The following is a description of a gene set: The process whose specific outcome is the progression of the dorsal region of the spinal cord over time, from its formation to the mature structure. The dorsal region of the mature spinal cord contains neurons that process and relay sensory input. Mouse Gene Set: GOBP_DORSAL_SPINAL_CORD_DEVELOPMENT studied in species Mus musculus, and this is the list of marker genes: Gdf7, Pbx3, Lhx3, Pax3, Ascl1, Gsx2, Lmo4, Gdnf, Draxin, Tal1, Lhx1, Wnt1, Daam2, Uncx, Pax7, Wnt3a, Lhx5, Hoxb8, Drgx, Gsx1, Lbx1 (NCBI Gene Id 16814)